Given this list of marker genes EP300, HOXA13, VPS35L, IFT56, FGFR2, FGFR1, CANT1, ABCC9, ACVR1, TWIST1, NEK1, VAC14, FIG4 (FIG4 phosphoinositide 5-phosphatase), here is a description of the gene set: An anomaly of the first metatarsal bone. species: Homo sapiens Abnormality of the first metatarsal bone Human Gene Set: HP_ABNORMALITY_OF_THE_FIRST_METATARSAL_BONE